The following is a description of a gene set: TNFR1-mediated ceramide production studied in species Mus musculus Mouse Gene Set: REACTOME_TNFR1_MEDIATED_CERAMIDE_PRODUCTION, and this is the list of marker genes: Smpd3, Tnfrsf1a, Rack1, Tnf, Smpd2 (NCBI Gene Id 20598), Nsmaf